Given this list of marker genes CPS1, OTC, CA5A, ASL, ATP5F1A, PNPO, ALDH18A1, ASS1, here is a description of the gene set: species: Homo sapiens Hypoargininemia A decreased concentration of arginine in the blood. Human Gene Set: HP_HYPOARGININEMIA